The following is a description of a gene set: This event has been computationally inferred from an event that has been demonstrated in another species.<p>The inference is based on the homology mapping from PANTHER. Briefly, reactions for which all involved PhysicalEntities (in input, output and catalyst) have a mapped orthologue/paralogue (for complexes at least 75% of components must have a mapping) are inferred to the other species. studied in species Mus musculus electronically inferred by orthology from the curated human pathway part of: Respiratory electron transport Reactome Pathway: Complex IV assembly, and this is the list of marker genes: Cox4i2, Cox6c, Cox5a, Cox8c, Tmem177, Coa5, Cox4i1, Cox7a1, Cox14, Higd2a, Cox7a2l, Cox6a1 (NCBI Gene Id 12861), Coq10a, Sco2, Cox8a, Ndufa4, Cox11, Cox7c, Cox20, Cox6a2, Cox17, Cox18